Given this list of marker genes STARD5, PDE2A, SERPINF2, SORD, PTH1R, RAMP3, N4BP2L1, CDO1, COBLL1, ACO1, here is a description of the gene set: from publication Boyault S, Rickman DS, de Reyniès A, Balabaud C, Rebouissou S, Jeannot E, Hérault A, Saric J, Belghiti J, Franco D, Bioulac-Sage P, Laurent-Puig P, Zucman-Rossi J (PMID 17187432) studied in species Homo sapiens Human Gene Set: BOYAULT_LIVER_CANCER_SUBCLASS_G23_DN Down-regulated genes in hepatocellular carcinoma (HCC) subclass G23, defined by unsupervised clustering. Hepatocellular carcinomas (HCCs) are a heterogeneous group of tumors that differ in risk factors and genetic alterations. We further investigated transcriptome-genotype-phenotype correlations in HCC. Global transcriptome analyses were performed on 57 HCCs and 3 hepatocellular adenomas and validated by quantitative RT-PCR using 63 additional HCCs. We determined loss of heterozygosity, gene mutations, promoter methylation of CDH1 and CDKN2A, and HBV DNA copy number for each tumor. Unsupervised transcriptome analysis identified 6 robust subgroups of HCC (G1-G6) associated with clinical and genetic characteristics. G1 tumors were associated with low copy number of HBV and overexpression of genes expressed in fetal liver and controlled by parental imprinting. G2 included HCCs infected with a high copy number of HBV and mutations in PIK3CA and TP53. In these first groups, we detected specific activation of the AKT pathway. G3 tumors were typified by mutation of TP53 and overexpression of genes controlling the cell cycle. G4 was a heterogeneous subgroup of tumors including TCF1-mutated hepatocellular adenomas and carcinomas. G5 and G6 were strongly related to beta-catenin mutations that lead to Wnt pathway activation; in particular, G6 tumors were characterized by satellite nodules, higher activation of the Wnt pathway, and E-cadherin underexpression. CONCLUSION: These results have furthered our understanding of the genetic diversity of human HCC and have provided specific identifiers for classifying tumors. In addition, our classification has potential therapeutic implications because 50% of the tumors were related to WNT or AKT pathway activation, which potentially could be targeted by specific inhibiting therapies.